Given this list of marker genes COMT, MLLT6, DRD2, ATP6V1B1, SPX, AGTR1, EDN1, CORIN, NPPB, NPR1, AGT, EDNRB (NCBI Gene Id 3282), here is a description of the gene set: species: Homo sapiens Human Gene Set: GOBP_RENAL_SODIUM_EXCRETION The elimination of sodium ions from peritubular capillaries (or surrounding hemolymph in invertebrates) into the renal tubules to be incorporated subsequently into the urine.